Given this list of marker genes HAP1, MAP2, LAMP1, FEZ1, TRIM58, NEFH, BORCS5, TRIM46, STK11, here is a description of the gene set: studied in species Homo sapiens Human Gene Set: GOBP_REGULATION_OF_ORGANELLE_TRANSPORT_ALONG_MICROTUBULE Any process that modulates the frequency, rate or extent of organelle transport along microtubule.